The following is a description of a gene set: from publication Cui A, Huang T, Li S, Ma A, Pérez JL, Sander C, Keskin DB, Wu CJ, Fraenkel E, Hacohen N (PMID 38057668) Mouse Gene Set: CUI_T_CELL_CD8_IL7_RESPONSE_UP studied in species Mus musculus Cytokines mediate cell-cell communication in the immune system and represent important therapeutic targets. A myriad of studies have highlighted their central role in immune function, yet we lack a global view of the cellular responses of each immune cell type to each cytokine. To address this gap, the authors created the Immune Dictionary, a compendium of single-cell transcriptomic profiles of more than 17 immune cell types in response to each of 86 cytokines (>1,400 cytokine-cell type combinations) in mouse lymph nodes in vivo. A cytokine-centric view of the dictionary revealed that most cytokines induce highly cell-type-specific responses. For example, the inflammatory cytokine interleukin-1β induces distinct gene programmes in almost every cell type. A cell-type-centric view of the dictionary identified more than 66 cytokine-driven cellular polarization states across immune cell types, including previously uncharacterized states such as an interleukin-18-induced polyfunctional natural killer cell state. Genes positively differentially expressed in cell type: CD8+ T cell upon treatment with cytokine: IL-7 in mouse lymph nodes in vivo., and this is the list of marker genes: Hnrnpu, Alyref, Uqcr11, Mybbp1a, Cd48, Nip7 (NCBI Gene Id 76155), Arhgdia, Aven, Psme2, Mbd2, Polr2f, Sem1, Hsp90aa1, Atf4, Tmed10, Rab5c, Edf1, Plac8, Eif1ax, Pcbp1, Rrp9, Znhit6, Sfxn1, Pdcd5, Pum3, Set, Fkbp4, Mthfd1, Adh5, Wdr46, Slc25a5, Nudt5, Nme1, Psmb5, Cyc1, Eif5a, G3bp1, Ndufb7, Ftsj3, Lta, Uqcrq, Gart, Psph, Ube2m, Pole4 (NCBI Gene Id 76037), Hdgf, Cox7b, Utp18, Ptma, Ung, Socs1, Tars1, Ddx39b, Exosc5, Grwd1, Psma5, Galk1, Vdac2, Dnajc2, Cct2, Snrpf, Ruvbl1, Ube2s, Umps, Tmed5, Eif4ebp1, Stip1, Prpf31, Cfl1, Inpp4b, Atp5mc1, Polr1d (polymerase (RNA) I polypeptide D), Higd1a, Timm13, Atp5f1d, Bzw1, Ranbp1, Ndufb4, Mrpl51, Vim, Atp5mk, Yars1, Eif3a, Rwdd1, Cish, Lsm4, Bax, Ddx18, Srsf7, St13, Aars1, Rars1, Npm1, Anp32b, Lsm2, Iars1, Nop10, Prmt7, Slc29a1, Nop14, Isg15, Gadd45gip1, Eif1, Dad1, Psmd7, Etf1, Dnaja2, Cct3, Rrp1, Uqcrb, Noc2l, U2af1, Rnf213, Ipo5, Mrpl12, Igfbp4 (insulin-like growth factor binding protein 4), Sigmar1, Ifi47, Nolc1, Ppa1, Txn2, Atad3a, Mbd3, Cox5b, Gtpbp4 (GTP binding protein 4), Comtd1, Map3k8, Wdr12, Srsf3, Ruvbl2, Sumo2, Cox5a, Rexo2, Tnfrsf18, Timm10, Vars1, Mdn1, Arpp19, Calr, Cycs, Mthfd2, Cacybp, Uck2, Eprs1, Ak2, Ddx39a, Ppia, Dkc1, Mrps14, Dynll1, Pfn1, Pfdn2, Ssb, Aimp2, Gnl3, Glipr2, Bzw2, Erh, Psma7, Ptges3, Glrx5, Cdv3, Mrpl36, Fam162a, Coro2a, Impdh2, Phb2, Nmi, Atp5mc3, Tomm40, Tmem238, Prdx1, Rbm8a, Pfdn6, St6galnac4, Hspd1, Stat1, Ltb, Mettl1, Jund, Banf1, Psma3, Tuba1b, Arl4c, Zfp593, Mrpl42, Eef1e1, Hspa9, Surf2, Pim2, Hnrnpf, Mif, Herpud1, Alkbh1 (NCBI Gene Id 72618), Aen, Sars1, Gcsh, Mrps24, Psmb3, Ssrp1 (NCBI Gene Id 97012), Chchd1, Brix1, Lsm12, Irgm1, Mrpl20, Ddx21, Ccnd2, Hspa8, Odc1, Park7 (NCBI Gene Id 57320), Ccdc86, Dph3, Pop5, Psat1, Agpat3, Pus7, Igtp, Pgam1, Eif4a1 (eukaryotic translation initiation factor 4A1), Nop56, Taf10, Tcof1, Ddit3, Nop16, Ahsa1, Rbx1, Fabp5, Tkt, Eif4e, Fbl, Glrx3, Cct7, Atp5pf, Rsl24d1, Rrp1b, Eif3d, Clic4, Aldh18a1, Grpel1, Serbp1, Ddx27, Flt3l, Cct8, Zbp1, Ndufc2, Larp1, Mrto4, Bysl, Rrp15, Apex1, Dbnl, Snx3, Gars1, Ndufaf4, Lsm7, Cdk6, Phgdh, Rsl1d1, Snu13, Casp8, Ms4a4b, Syncrip, Mrps28, Cnbp, Krtcap2, Mphosph10, Eif1a, Lsm6, Hspa5, Pgk1, Psmb6, Eif2s1, Rrs1, Eif5b, Nars1, Mrpl30, Mrpl23 (NCBI Gene Id 19935), Jaml, Eif3b, Fubp1, Timm8a1, Mat2a, Mrpl17, Rras2, Chchd2, Ndufab1, Tpi1, Ndufs7, Pim1, Psma4, Psmc5, Eif3j1, Hnrnpd, Nsun2, Prmt1, Lars1 (NCBI Gene Id 73060), Gapdh, Polr1g (NCBI Gene Id 70333), Znrd2, Psmb2, Mdh2, Aatf, Snrpb, Snrpa1, Npm3, Uchl3, Snrpa, Lap3, Uqcc2, Tmem147, Mak16, Cdk4 (cyclin dependent kinase 4), Wdr43, Cdca7, Ifi35, Atp5f1b, Strap, Ppid, Tomm5, Ybx1, Tubb4b, Cd8a, Atic, Eif6, Mrpl15, Myc, Mydgf, Psmb8, Tpm3, Ly6a, Mrps18b, Hsp90ab1, Srm, Cndp2, Tmed2, Selenow, Eloc (NCBI Gene Id 98484), Cdc37, Gspt1 (G1 to S phase transition 1), Rcl1, Eif3c, Ebna1bp2, C1qbp, Bst2, Lgals3bp, Cars1, Timm50, S100a13, Ifrd2, Cyba, Nudc, Mrpl21, Nhp2, Hspe1, Pa2g4, Socs3 (suppressor of cytokine signaling 3), Gpatch4 (G patch domain containing 4), Snrpd3, Ppp1r14b, Ndufa12 (NCBI Gene Id 66414), Aprt, Hspbp1, Psmb10, Pebp1 (phosphatidylethanolamine binding protein 1), Ltv1, Trp53, Hnrnpab, Mrps15, Slc7a5 (solute carrier family 7 (cationic amino acid transporter, y+ system), member 5), Ctps1, Ncl, Eif4a3, Phb1, Bccip, Timm9, Tbca, Llph, Lyar, Gar1, Magoh, Nop58, Fyn (NCBI Gene Id 14360), Txnl4a, Sco2, Slc7a1, Mars1, Samhd1, Stoml2, Abce1, Ppan, Psma2, Srsf2, Nop2, Rcc2, Tubb5, Eif3g, Dcun1d5, Sub1, Eif2s2, Wdr83os, Eno1, Ran, Kpnb1, Hspa4, Slc3a2, Bcl2, Rpf2, Romo1, Ldha, Capg (capping actin protein, gelsolin like), Tuba4a, Ppat, Cox6a1, Snrpd1, Txn1, Emc6, Dctpp1, Polr2h, Shmt2, Tcp1, Ostc, Cct5, Nifk